The following is a description of a gene set: Type 1 IFNs can conditionally activate all of the signal transducers and activators of transcription molecules (STATs), including STAT4. The best-characterized signaling pathways use STAT1, however, and type 1 IFN inhibition of cell proliferation is STAT1 dependent. We report that type 1 IFNs can basally stimulate STAT1- and STAT4- dependent effects in CD8 T cells, but that CD8 T cells responding to infections of mice with lymphocytic choriomenigitis virus have elevated STAT4 and lower STAT1 expression with significant consequences for modifying the effects of type 1 IFN exposure. The phenotype was associated with preferential type 1 IFN activation of STAT4 as compared to STAT1. Stimulation through the TCR induced elevated STAT4 expression, and STAT4 was required for peak expansion of antigen-specific CD8 T cells, low STAT1 levels, and resistance to type 1 IFN-mediated inhibition of proliferation. Thus, a mechanism is discovered for regulating the consequences of type 1 IFN exposure in CD8 T cells, with STAT4 acting as a key molecule in driving optimal antigen-specific responses and overcoming STAT1-dependent inhibition of proliferation. from publication Gil MP, Ploquin MJ, Watford WT, Lee SH, Kim K, Wang X, Kanno Y, O'Shea JJ, Biron CA (PMID 22968462) Human Gene Set: GSE40666_WT_VS_STAT1_KO_CD8_TCELL_DN Genes down-regulated in CD8 T cells: wildtype versus STAT1 knockout. species: Homo sapiens, and this is the list of marker genes: BHLHE40, IKZF2, CATSPERD, CELA1, SMOX, MRS2, SLC22A15, CST7, CCRL2, ARAP3, DSE, FBXO22, POGLUT3, IFT27 (NCBI Gene Id 11020), RRP1B, TOX2, G6PC3, FAM3C, ELOA, SCARB1, SYTL3, INPPL1, AMZ1, BEND3, TBC1D5, TSPAN4, TASL, MBOAT7, SLC28A2, ISYNA1, BLTP3A, ACP3, TTYH2, SLC43A2, SHISA2, MRPL12, SMYD5, CTSC, RHOD, CERK, CD160, SEMA3E, REXO2, MAFG, ABHD4, FAM234A, TRPM6, NFIC, IMP4, SQOR, CRMP1 (NCBI Gene Id 1400), WWP1, ECI1, GCAT, HLCS, RELL2, SRGN, PTPRJ, SEC24D, ARHGAP26, TMEM126A, APOBR, DIPK2A, FGD5, RNF43, SERPINB9, TMEM64, SH2D2A, RPS19BP1, PON3, PHGDH, ACOT11, NFKBIA, CCR10, CRELD2, SOCS5, ZNF23, TSHZ3, GBP4, AGPAT2, PTGES2, THTPA, GDPD5, CDKN2B, TMEM115, CX3CR1, YBX3, TDRD7, ERO1A, SERF1A, MSTO1, LYN, PARD6B, HGSNAT, F2R, PTPN9, ALS2, SOCS7, PLS1, SMIM3, MAF, DTNBP1, SLC12A2, RRP36, RNH1, LGI2, FURIN, RAB4A, TXNRD2, EGR3, NRP1, UNC119, PCTP, ZC3H7B, IFI30, PRELID3B (PRELI domain containing 3B), MAGED1, TMTC4, AHR, PLSCR1, APLP1, SPRY2, TLE4, B4GALNT4, BID, QPCT, PLEKHG3, SH2D1A, NAGA, GPN1, DAGLB (NCBI Gene Id 221955), GNA12, C1orf122, GABARAPL1, COMTD1, PRMT3, FAM167A, VAMP5, LYSMD2, ICAM1, ZBED5, ANKRD63, PHYKPL, TM6SF1, PTPN13 (protein tyrosine phosphatase non-receptor type 13), FZD6, RORA, CCDC126 (coiled-coil domain containing 126), NR2F6, GK (glycerol kinase), VTI1B, BLK, METTL1, TNFRSF1B, NFKBIE, BAHD1, TNFRSF21, CD38, TLCD2, HIP1R, COBLL1, TNFSF10, NCF4, CIB2, RNF19B, CRTAP, RPL6, PXDC1, PPP1R14B, IL18RAP, AKR1E2 (aldo-keto reductase family 1 member E2), LITAF, PRKAR2A, TJP2, C12orf75, NSMAF, DHRS11, EEF2K, RNPEP, RNASET2, ADH1C, PPIC, ACYP2, MYO6, SDAD1, RASGEF1B, MRPL38, C6orf89, ADAM19, FARP1, TMEM243, S100A10, TGIF1, NUCB1, VDR, SMCO4, EIF3B, FUCA2, TLCD3A, TMEM140